Given this list of marker genes IL1B, MYLK3, TGFBR1, ABCC8, TGFB3, here is a description of the gene set: Human Gene Set: GOBP_REGULATION_OF_TIGHT_JUNCTION_DISASSEMBLY Any process that modulates the frequency, rate or extent of tight junction disassembly. species: Homo sapiens